The following is a description of a gene set: Genes predicted to be targets of miRBase v22 microRNA hsa-miR-1231 in miRDB v6.0 with MirTarget v4 prediction scores > 80 (high confidence targets). Human Gene Set: MIR1231 studied in species Homo sapiens from publication Chen Y, Wang X (PMID 31504780), and this is the list of marker genes: SMG6, MYOZ3, ELAVL4, CREB3L3, DPP3, ONECUT2, SHISA7, TIAM1, SLC12A1, PSIP1, CC2D1A, UGT2A1, MECP2, BTRC, VRK2, HDGF, CLOCK, PTCHD4, TMEM115, RRAS2, KPNA6, CEP43, NTNG1, WIPF1, SEC13, ATP8B1, ITGBL1 (integrin subunit beta like 1), ZNF174, SOST (NCBI Gene Id 8149), UIMC1, PRDM16, FNIP2, BTN3A2, TPD52L3, GLG1, KCMF1, TNRC18, BMAL1, SOX12, POLR1F, UGT2A2, NAA15, ARL5A, QKI, CTDSPL, HIVEP3, LYRM1, AZIN1, GOPC, TTC28, PPM1E, EIF4B